The following is a description of a gene set: Human Gene Set: SABATES_COLORECTAL_ADENOMA_DN Colorectal cancers are believed to arise predominantly from adenomas. Although these precancerous lesions have been subjected to extensive clinical, pathologic, and molecular analyses, little is currently known about the global gene expression changes accompanying their formation. To characterize the molecular processes underlying the transformation of normal colonic epithelium, we compared the transcriptomes of 32 prospectively collected adenomas with those of normal mucosa from the same individuals. Important differences emerged not only between the expression profiles of normal and adenomatous tissues but also between those of small and large adenomas. A key feature of the transformation process was the remodeling of the Wnt pathway reflected in patent overexpression and underexpression of 78 known components of this signaling cascade. The expression of 19 Wnt targets was closely correlated with clear up-regulation of KIAA1199, whose function is currently unknown. In normal mucosa, KIAA1199 expression was confined to cells in the lower portion of intestinal crypts, where Wnt signaling is physiologically active, but it was markedly increased in all adenomas, where it was expressed in most of the epithelial cells, and in colon cancer cell lines, it was markedly reduced by inactivation of the beta-catenin/T-cell factor(s) transcription complex, the pivotal mediator of Wnt signaling. Our transcriptomic profiles of normal colonic mucosa and colorectal adenomas shed new light on the early stages of colorectal tumorigenesis and identified KIAA1199 as a novel target of the Wnt signaling pathway and a putative marker of colorectal adenomatous transformation. Genes down-regulated in colorectal adenoma compared to normal mucosa samples. from publication Sabates-Bellver J, Van der Flier LG, de Palo M, Cattaneo E, Maake C, Rehrauer H, Laczko E, Kurowski MA, Bujnicki JM, Menigatti M, Luz J, Ranalli TV, Gomes V, Pastorelli A, Faggiani R, Anti M, Jiricny J, Clevers H, Marra G (PMID 18171984) studied in species Homo sapiens, and this is the list of marker genes: EDN3, SCNN1B, CES2, PCDH19, CFH, RERG, FN1, TMEM72 (transmembrane protein 72), ATP1A2, NCF1, KNG1, CXCL13, EPHA3, NEXMIF, VPREB3, MYOT, PPY, KCTD12, FEV, L1CAM, CA1, SLC4A4, LAMA1, PTN, ACKR1, AKAP12, ANK2, XKR4, LGALS2, LMOD1, B3GALT5-AS1, FABP4 (fatty acid binding protein 4), ADCY2, NEUROD1, TRGC1, ANO5, DHRS11, EPHA7, IGF1, CHRNA1, SLC51B, SLC26A2, FMN2, PDE3A, STAP1, EPB41L3, KCNIP4, ZNF536 (NCBI Gene Id 9745), TRAF3IP3, CA4, SPINK5 (NCBI Gene Id 50962), CHP2, F13A1, NR5A2, C7, FCRL3, CHODL, TTR, AFF3, CLU, PRKCB, TNXA, TNS1, BTNL8, CDKL1, COLEC12, FDCSP, CLDN23, GCG, TMOD2, HOXD10, MYH11, IL6R, TP53INP2, IGHA1, RSPO2, ADH1B, CD48, NAP1L2, CCL13, ASPA, MIR100HG, RAB3B, PI15, PLP1, PYY, PNLIPRP2, CLDN8, GPX3, PDE6A, SLC22A4, TMEM171, SLC15A1, CHRDL1 (chordin like 1), DPP10-AS1, SLC17A4, AMPD1, TMCC3, JAM2, FXYD1, ASPN, MS4A8, MS4A1, TMEM255A, PLAAT2, BEND5, SCN7A, SLC6A19, SORBS2, SCNN1G, INSM1, TUSC3, NHERF4, NDN, PRIMA1, CPM, ZBTB16, OGN, MYLK, CLEC3B, PTPRR, DOCK10 (NCBI Gene Id 9714), PCDH7, FCRLA, OR51E2, NAALADL1, HSD17B2, CHGB, TLR7, CA7, SPIB, CDA, ARHGAP15, CHGA, CTSG, CLCA4, SV2B, PCDH9, TRPM6, ANGPTL1, MFAP4, AQP8, SCN9A, NAP1L3, LPAR1, MT1M, SFRP1 (secreted frizzled related protein 1), CNNM2, PCK1, GPM6B, ALPI, TBC1D9, C2orf88, SOX10, SECTM1, EDIL3, FLRT2 (NCBI Gene Id 9822), SYNE3, SEMA6D, PLAC9, WASF3, CHAD (NCBI Gene Id 1101), TPH1, CEACAM7, GLDN, ITGA4 (integrin subunit alpha 4), LINC02023, KIF5C, LYPD8, DUSP1, CPB1, BMP3, VIP, GUCA2B, HSD3B2, MEP1B, GFRA3, ZG16, SLC25A34, RBM24, TRDC, CDH19, TSPAN7, TMEM200A, COL14A1, CCL8, SI, FAM107A, BCHE, LYVE1, LIFR, SLC9A3, DSEL, GPNMB, CYTL1, CRYBA2, ENPP6, GPC6, PHLPP2 (PH domain and leucine rich repeat protein phosphatase 2), SETBP1, ZNF667-AS1, ABCA8, GBA3, CYP3A4, AOC3, CMAHP, TNFRSF17, PRKAA2, B3GALT5, CD177, BMP5, MFAP5, RFX6, RUNDC3B, CCL5, ZNF483, SYNPO2, FBLN1, TM6SF2, BRINP3, CD36, CCL19, GREM2, CCL21, LRRN2, SCG2 (secretogranin II), OSR1, WNT2B, LRRK2, CP, ANPEP, PGM5-AS1 (NCBI Gene Id 572558), MEIS1, SLC51A, EFEMP1 (EGF containing fibulin extracellular matrix protein 1), ABI3BP, CNTN4 (contactin 4), VSTM2A, SPINK2, PLA2G12B, PAG1, USP2, TEX11, CD37, RTN1, TNFRSF13C (TNF receptor superfamily member 13C), IGHM, MAMDC2, TMEM140, NPY, SST, FCMR, SCGN, SCARA5, SORCS1, CDKN2B-AS1, CXCL12, CCL23, MS4A12, CDHR5, SIT1, MEOX2, CCDC80, WSCD1, DPP10, ECRG4, CR2, ADAMDEC1, CDKN2B, ITIH5, NRXN1, BEST4 (bestrophin 4), NLGN4X, CNN1, GCNT2, GHR, TMEM100 (transmembrane protein 100), CA2, MST1, FAM13C, THRB, SIGLEC1, DPT, RSPO3, HAPLN1, ABCG2, PKIB, MFSD4A, MCOLN2, LINC01082, UNC5C, CPNE8, GUCA2A, XPNPEP2, GDPD2, UGT2B17, UGT2B15, INSL5, PDZK1